Given this list of marker genes DNAH11, FGFR1, PTPRZ1, BRIP1, HMGN5, USP36, GRAPL-AS1 (GRAPL antisense RNA 1), ABI3, DCANP1, CST1, IL18R1, SIAH1, NSUN3, ANKFY1, CELP, CDH22, MTMR12, NR2E1 (NCBI Gene Id 7101), PRDM8, ELOVL2, ITK, ATG4D, DCTN3, SENP1, PARS2, ZNF117, BSDC1, MAPKBP1, PYCR3, RRAGD, MOB4, PPP1CB (protein phosphatase 1 catalytic subunit beta), LNPK, SEMA4A, MRPS15 (NCBI Gene Id 64960), CCL11, GABARAPL2, FNBP4, NADSYN1, FBXW4, AMZ2, LMTK3, CELF2, PAPOLA, PLEKHG1, CHST9, CITED2, CDH4, TIMP3, SLMAP, TMEM62 (NCBI Gene Id 95722), MORC3, SARAF, TRIM14, ARHGAP45, MYEF2, SLC26A8, NCOA7, INO80B, CD163, CSF1, WDR46, TIMP4, BPIFA1, S100A5, ZFP41, CEP162, DNAAF4, GPATCH3, NFIL3, FGD6, FAM220A, KDM5B, MPRIP, XRN2, AURKAIP1, VIT, MRPL47 (mitochondrial ribosomal protein L47), EPCIP, LYL1, ANKRD13A (NCBI Gene Id 88455), MICB, LEPROTL1, TBC1D8B, LY9 (NCBI Gene Id 95630), NUTM2F, DNAJA1P5, DZIP3, ITM2C, TMEM97, SNX5, QKI, ELAC1, ZNF264, ACKR1 (NCBI Gene Id 2532), DIRAS2, RPRM, ANXA1, C17orf75, RERE, NME1, EPHA7, PHAX, MST1R, CMTM6, MRPL18, CCDC134, UGCG, BCL2L13, EPHB6, BGN, TMEM47, TAL1, PTPRT, C1orf116, MMP7, CD1D, KLHL36, EPB41L4B, CBLN1, PLIN1, NELFB, GOLGA5, BAG3, EIF2B4, GEM, BCL2L14, ITGAM, LAP3, NEPRO, MXRA8, RBM7, BASP1, CCNL1, STAMBPL1, SCD, MICALL1, CDH5, ARHGAP20, ISYNA1, SLC25A27 (solute carrier family 25 member 27), EREG (epiregulin), IPCEF1, TFPI2, EEF1D, ITGB5, RNF213, ACTR6, LRRN3, OXGR1, HOMER2, STAT3, LRRC14, MFSD1, SOX6, CHL1, MYL12A, KATNAL1, KAT2B, PKIA, DHODH, TMEM255A, DPYD, KIAA2013, PRPF39, SMAD3, KDM4D, AASS, BTN2A1, SAV1, AMIGO1, PAQR5, ATG2A, WDR25, FMN1, ACE, PITPNC1, ESPN, NXPH4, DIO3, GPSM3, NUP58, DCAF15, BAIAP3 (NCBI Gene Id 8938), FAF1, CCDC90B, CCAR2, PPP1R14D, SDC3, TIMELESS, EPS15L1, DCLK1, NRL, OSBPL9, SLC43A1, GPR68, LANCL2, GSTM1, ERMN, ADIPOR2, XPO4, VNN1, CYYR1, AGAP2, PIF1, TRIM48, BCR, UTP11, POGLUT2, ALDH1B1, NHSL3, PTGS2, KLHL4, ERLIN2, TMEM161A, PNMA8A, FUCA1, ADAMTS3, CYP1A1, ACVR1, MAL2, LYZ, TNFRSF13C, IL1A, ALKBH4, LRRC4C, OBSCN, ATP8A2, SLC22A3, DDX60, CACNA2D3, TMT1A, TSLP, PYGB (NCBI Gene Id 5834), NCF2, BFSP2-AS1, UNC79, DLC1, ILRUN, ZNF318, SP140L, PGLYRP2, ZNF566, PTPRF, MBD5, EARS2, LARP1, ATG16L1, COPE, FABP2, PLEKHM2, SLC19A1, EYA3, GSN, LRRC19, SV2B (synaptic vesicle glycoprotein 2B), CYP2A7, PPP4R2, COCH, HIVEP2, IL1R2, DEXI, HIF1A, MRPL27, GJA1, CHST1, CLUH, SMG7, MED28, BRAP, ATRN, GLB1L, ALDOA, GJA5, PIP4K2C, ZKSCAN7 (NCBI Gene Id 80241), WRNIP1, CXCL8, QSER1 (glutamine and serine rich 1), AHNAK, LINC00160, PDE4D, FAM169A, NEIL1, SPMAP2, TMCC2, POU6F2, OR7E12P, PCGF1, BEGAIN, PAWR, TMEM120A, ABHD17C, SFRP1, DYNC2LI1, ZNF107, ZMYM5, IL1RL1, WDR19, CDK11A, RNF220, CEBPZ, KCNE4, TMED3, SH2B3, ACSL1, TRIM7, ACSM5, ERVMER34-1, FOS, ARHGAP15, FAIM, TMEM250, LRP3, TOR4A, MCMBP, LY86, CCDC81, FBXO11, SLITRK1, COQ8A, SPSB4, CORIN (corin, serine peptidase), MAP2K6, YWHAB, TMEM248, PDCD2L, AMY2B, ITGA4, KATNIP, NELFCD, GEMIN7, CIP2A, NOP53, UFSP2 (NCBI Gene Id 55325), TUBA4A, NANS, GPR26, TMEM121B, TNFSF4, SLC11A2, PDCD6, SIPA1L3, TDP1, GOLGA4, REPIN1, MMP9, KLHL41, NGF (nerve growth factor), MCTS1, GJC2 (NCBI Gene Id 57165), MED25, STRIP2, FAR2 (NCBI Gene Id 55711), HNRNPDL, CCBE1, PHIP, SURF6, AMOTL2, ZGRF1, PLAAT4, CXCL10, SQOR, COL6A3, RPAP3, NOL7, PLEKHF2, SUGP2, CNOT6L, LACTB, NECAP2, SNRNP25, ZCCHC4, MMP14, ZMAT4, OR2A1, FURIN, STRN (NCBI Gene Id 6801), TRABD (TraB domain containing), GABPB1-IT1, ZNF143, HS1BP3, PORCN, ZDHHC2, ATXN7, CHD9, DES, RNASE6, SLAMF7, ART3, EFCC1, POLDIP3, ZBTB5, KRT19, MOCOS, MREG, HACD1, FPR2, TMLHE, ARID5A, ITGB1, ASXL2 (NCBI Gene Id 55252), CD8A, TMEM144, TP53, TBC1D9, PCED1B, NUP54, TLN1, REV3L (NCBI Gene Id 7807), PI4K2B, RNASEL, CAND1, FLJ13224, TTF2, C19orf73, CCL2, CUL9, NACAD, FN1, INIP, CD1A, SSBP4, CLCF1, MAPK4, OTOR, ELOB, ALG6, MLYCD, MAGED4B, SELP, APTX, HBE1, PTX3, RNF103, MED12L, CDK16, CSF2RB, SLC17A8, PLGLB2, MRPL36, PRDM1, SPNS1, SCARA3, CCDC85C, CTSZ, AKAP8L, TESPA1, LDAH (lipid droplet associated hydrolase), ARG1, CHD1, here is a description of the gene set: studied in species Homo sapiens Genes in the cancer module 255. Human Gene Set: MODULE_255